The following is a description of a gene set: Cluster 6: ECM related genes up-regulated in dermal fibroblasts later than 30 min after TGFB1 addition; slowly increased up to 120 min time point, then reached a plateau. Human Gene Set: VERRECCHIA_RESPONSE_TO_TGFB1_C6 from publication Verrecchia F, Chu ML, Mauviel A (PMID 11279127) Despite major advances in the understanding of the intimate mechanisms of transforming growth factor-beta (TGF-beta) signaling through the Smad pathway, little progress has been made in the identification of direct target genes. In this report, using cDNA microarrays, we have focussed our attention on the characterization of extracellular matrix-related genes rapidly induced by TGF-beta in human dermal fibroblasts and attempted to identify the ones whose up-regulation by TGF-beta is Smad-mediated. For a gene to qualify as a direct Smad target, we postulated that it had to meet the following criteria: (1) rapid (30 min) and significant (at least 2-fold) elevation of steady-state mRNA levels upon TGF-beta stimulation, (2) activation of the promoter by both exogenous TGF-beta and co-transfected Smad3 expression vector, (3) up-regulation of promoter activity by TGF-beta blocked by both dominant-negative Smad3 and inhibitory Smad7 expression vectors, and (4) promoter transactivation by TGF-beta not possible in Smad3(-/-) mouse embryo fibroblasts. Using this stringent approach, we have identified COL1A2, COL3A1, COL6A1, COL6A3, and tissue inhibitor of metalloproteases-1 as definite TGF-beta/Smad3 targets. Extrapolation of this approach to other extracellular matrix-related gene promoters also identified COL1A1 and COL5A2, but not COL6A2, as novel Smad targets. Together, these results represent a significant step toward the identification of novel, early-induced Smad-dependent TGF-beta target genes in fibroblasts. studied in species Homo sapiens, and this is the list of marker genes: COL8A1, EPHB4, NEO1 (NCBI Gene Id 4756), IGFBP4, DSP